Given this list of marker genes MIR6878, PDZK1, RNVU1-14, RNY4P25, ENSG00000227733, PFN1P8, LINC02799, GOLPH3L, TDRKH, RORC, TDRKH-AS1, ENSG00000303408, NOTCH2NLB, GABPB2, BCL9, LINC01632, PDIA3P1, ENSG00000229699, LAPTM4BP1 (lysosomal protein transmembrane 4 beta pseudogene 1), LINC01145, PDE4DIPP6, PIAS3, H3-7, SEC22B4P, ECM1, GJA8, GPR89B, POGZ, KMT2CP1, PRUNE1, ENSG00000252682, PGLYRP4, HYDIN2, RNVU1-15, NBPF13P, FLG2, RN7SL261P, S100A6, HJV, H2BP2, CIART, PEX11B, VPS45, RNF115, ENSG00000291199, SETDB1, POLR3C, S100A7L2, S100A15A, RNA5SP57, RNU1-154P, MRPL9, FAM91A3P, RN7SL444P, RNU6-1042P, RNU6-1171P, RFX5-AS1, NBPF10, RN7SL372P, SELENBP1, RNU1-68P, RN7SL480P, LCE1C, RNVU1-2A (RNA, variant U1 small nuclear 2A), RNVU1-22, PDE4DIPP1, UBE2Q1-AS1, SRGAP2D, SPRR2D, LCE1A, MIR554, CERS2, NOTCH2NLC, C1orf54, ADAM15, SSBL4P, RNVU1-18, LIX1L-AS1, IL6R, ACP6, LCE7A, OAZ3, CYCSP51, SCNM1, ENSG00000301230, ANP32E, UBE2Q1, ADAMTSL4-AS1, ENSA, CTSK, MIR6736, LINGO4, EFNA3, MINDY1, SRGAP2B, RNVU1-7, LCE3A, RNVU1-1, FMO5, LSP1P5, S100A13, BNIPL, RNU6-1309P, VPS72, KCNN3, SPRR1A, PFN1P6, TCHHL1, RNVU1-24, CCT8P1 (chaperonin containing TCP1 subunit 8 pseudogene 1), RNU6-1062P, MIR4257, AQP10, ENSG00000252840, ENSG00000294133, MCL1, ANKRD34A, LCE3E, H2AC19, RNU1-143P, ANXA9, DRD5P2, EFNA4-EFNA3, ZNF687 (NCBI Gene Id 57592), CFAP141, LINC01138, LINC02988, SPRR2C, PPIAL4D, ZBTB7B, RNU7-57P, NUDT4P2, SMCP, PUDPP2, ADAMTSL4-AS2, CELF3, RNVU1-21, TARS2, SEMA6C, JTB-DT, S100A14, PDZK1P1, LCE1D, POLR3GL, FCGR1A, LCE2B, RNU1-153P, RPL6P31, H3C15, NBPF12, FAM72C, CA14, ENSG00000306355, ENSG00000286391, TMOD4, PDE4DIPP7, LINC01527, SEC22B3P, LCEP4, RPTN, RPSAP17, LCE4A, PFN1P4, SPRR2B, NKAIN1P1, SLC39A1, ABHD17AP1, H2BC19P, ILF2, PSMB4, S100A16, OTUD7B, RNU6-662P (NCBI Gene Id 106479860), NBPF20, LCEP1 (late cornified envelope pseudogene 1), MIR190B, KMT2CP3, H4C14, NBPF25P, S100A8, PFN1P3, MTMR11, PDE4DIPP3, IVL, PSMD8P1, S100A9, NBPF11, PIP5K1A, SPRR2F, C2CD4D-AS1, LCEP2, LCE1B, C2CD4D, DCST1-AS1, MIR4258, TDRD10, H2BC18, H2AC20, GNRHR2, NPR1, CHTOP, CCDST, NUDT4B, FALEC, RNVU1-25, NBPF17P (NBPF member 17, pseudogene), MIR5087, THEM5, GJA5, NOTCH2NLA, RNU2-38P, S100A1, CDC42SE1, RNVU1-29, ENSG00000233030, SHC1 (NCBI Gene Id 6464), PYGO2, RPS27AP6, CRTC2, CKS1B, UBAP2L, RNVU1-28, H2BC20P, ATP8B2, LENEP, S100A7P1, CGN, CTXND2, OR13Z3P, SHE (NCBI Gene Id 126669), RN7SL431P, RNVU1-6, TNFAIP8L2, RN7SL473P, RPS29P29, NUP210L, NBPF9, FAM72D, TUFT1, LCE3C, CHRNB2, RPLP0P4, RNVU1-8, RNVU1-17, RNA5SP59, RNU6-239P, LCEP3, RNU6-1071P, LCE3D, KRT8P28, DCST2, H2AC21, SPRR2G, CRNN, PGLYRP3, SPRR5, RFX5, RBM8A, DENND4B, LINC00302, RNVU1-27, C1orf43, BOLA1, KPLCE, FAM91A2P, HAX1, PDE4DIP, LCE6A, S100A2, RN7SKP88, RNVU1-3, LCE1E, PDE4DIPP5, H2AC18, RNA5SP536, OR13Z1P, RNVU1-26, CD160, EFNA4, LYSMD1, ADAMTSL4, PPIAL4C, SPTLC1P4, LORICRIN, KMT2CP2, NUDT17, RNU6-160P, LCE3B, LINC00869, RNU6-179P, SEC22B2P, RNU6-884P, HMGN3P1, RNVU1-31, ANKRD35, MIR6077, PLEKHO1, NBPF15, LCE2C, ENSG00000288626, RNU2-17P, GEMIN2P1, MIR6737, LCE5A, PBXIP1, CHD1L, RPL22P5, LIX1L, LCE2A, IGKV1OR1-1 (immunoglobulin kappa variable 1/OR1-1 (pseudogene)), LELP1, RNA5SP529, CTSS, FLAD1, LINC02591, GPR89A, RNVU1-30, JTB, TCHH, S100A5, RIIAD1, HRNR, APH1A, CREB3L4, ARNT, FLG, TPM3, IL6R-AS1, CRCT1 (NCBI Gene Id 54544), PRR9, PPIAL4G (peptidylprolyl isomerase A like 4G), SPRR2A, SPRR4, INTS3, C1orf56, MIR8083, ZNF687-AS1, GATAD2B, S100A11, MRPS21, RPS7P2, LINC02802, ADAR, RNU6-121P, PFN1P12, ENSG00000252920, UBE2D3P3, S100A4, H4C15, RAB13, SNORA58B, RNA5SP533, RNU1-155P, LINC02806, SNAPIN, ENSG00000307187, ENSG00000285818, PI4KB, HORMAD1, S100A7A, SPRR1B, SV2A, NBPF14, OR13Z2P, THEM4, S100A10, MIR5698, H3C13, RNU1-114P, LINC00624, H2BC21, RNU1-129P, RNVU1-2, NBPF19, PRPF3, S100A12, SPRR2E (small proline rich protein 2E), RPRD2, MLLT11, RN7SL44P, NBPF18P, FCGR1CP (NCBI Gene Id 644410), RNVU1-23, PPIAL4F, SNX27, LCE2D, RNU1-151P, ITGA10, ENSG00000288880, SF3B4, PYGO2-AS1, ENSG00000284738, LCE1F, RPL7AP15, S100A3, KPRP, LINC01719, PSMD4, PMVK, H3C14, DCST1, S100A7, RPS27, PPIAL4E, SLC27A3, RN7SL600P, LINC02805, PRKAB2, TXNIP, SPRR3, PPIAL4H, here is a description of the gene set: Human Gene Set: chr1q21 species: Homo sapiens